Given this list of marker genes HGSNAT, here is a description of the gene set: Reactome Pathway: MPS IIIC - Sanfilippo syndrome C species: Homo sapiens Mucopolysaccharidosis III (Sanfilippo syndrome) was described in 1963 by a pediatrician named Sylvester Sanfilippo (J. Pediat. 63: 837838, 1963, no reference). Mucopolysaccharidosis type IIIC (MPS IIIC, Sanfilippo syndrome C; MIM:252930) is an autosomal recessive genetic disorder due to the loss of heparan alpha-glucosaminide N-acetyltransferase (HGSNAT; MIM:610453) that normally acetylates the non-reducing terminal alpha-glucosamine residue of heparan sulfate. The molecular defects underlying MPS IIIC remained unknown for almost three decades due to the low tissue content and instability of HGSNAT. But, during the last decade, the gene was cloned in parallel by two different groups and shown to contain 18 exons and span approximately 62Kb. Loss of HGSNAT results in build up of this glycosaminglycan (GAG) in cells and tissues and is characterized by severe central nervous system degeneration but only with mild somatic disease and death occurs typically during the second or third decade of life. part of: Mucopolysaccharidoses